The following is a description of a gene set: studied in species Homo sapiens Human Gene Set: GOMF_EXTRACELLULAR_MATRIX_PROTEIN_BINDING Binding to a protein that is part of an extracellular matrix., and this is the list of marker genes: MEPE, GABBR1, ITGAV, CLEC14A, CD248, ITGB8